The following is a description of a gene set: studied in species Homo sapiens Reactome Pathway: NGF-independant TRKA activation TRK receptors can also be activated by at least two G-protein-coupled receptors (GPCR), the adenosine A2a receptor and the PACAP type I receptor, without involvement of neurotrophins. Activity of both receptors is mediated by G proteins that activate adenyl cyclase. How this leads to TRKA activation has not been fully elucidated, although a SRC-family tyrosine kinase and intracellular Ca2+ appear to play a role. TRKA activation through GPCRs occurs with slow kinetics (over 1 hr adenosine or PACAP treatment is required) in an intracellular location (probably the Golgi apparatus), and requires transcriptional and protein synthesis events that may influence the processing and activation of the receptors. GPCR-mediated transactivation of TRK receptors causes the preferential activation of AKT versus ERKs. This leads to a cell survival response. part of: Activation of TRKA receptors, and this is the list of marker genes: ADCYAP1 (adenylate cyclase activating polypeptide 1), ADCYAP1R1, NTRK1, ADORA2A, NTRK2